Given this list of marker genes CFH, CFI, CHM, RPE65, PROM1, EFEMP1, LCA5, SPATA7, LRAT, here is a description of the gene set: Granular macular appearance Human Gene Set: HP_GRANULAR_MACULAR_APPEARANCE species: Homo sapiens Mottled (spotted or blotched with different shades) pigmentary abnormality of the macula lutea.